The following is a description of a gene set: Genes containing one or more binding sites for (ZNF445) in their promoter regions (TSS -1000,+100 bp) as identified by GTRD version 20.06 ChIP-seq harmonization. from publication Yevshin I, Sharipov R, Kolmykov S, Kondrakhin Y, Kolpakov F (PMID 30445619) Human Gene Set: ZNF445_TARGET_GENES studied in species Homo sapiens, and this is the list of marker genes: HNRNPH1, MGMT, ENOSF1, GEMIN7-AS1, CCDC144A, GET4, BLCAP, KCNT1